Given this list of marker genes MRC2, IRAK2 (NCBI Gene Id 3656), STK39, SEH1L, KRCC1, MYB, TM9SF3, ETF1, EIF4E, GRIPAP1, ZNF784, TESK2, UST, EIF4H, UBFD1, TMCC1, PKP4, SGMS1, TADA1, ACBD3, FBXW11, FOXP1, MAP3K12 (mitogen-activated protein kinase kinase kinase 12), STX5, GLDC, NAV2, PAFAH1B1, PAPPA, SRF, VAMP2, DYRK1A, GABRG2, IKBIP, MBD6, MMP19, ELK1, ICA1, MYADM, ERP44, PLXNC1, GTF3C2, ERC1, VEZF1, COL4A4, EDA, ZCCHC3, TAPT1, IFFO1, ZBTB4, FZD4, ACTR1A, ZMYM5, TSC22D3, RAD23B, BASP1, IGF1, EGR2, ARGLU1, ATAT1, HILPDA, EPHB2, PIGA, MMP14, KCNN3, GDI1, PRKAR1A, ZNF189, DUSP3, NOTCH3, C2CD2L, PRRT2, SMARCD1, PPP2CB, ARAP3, PLP2, CPD, PA2G4, YDJC, TRPS1, VEGFA, NR2F2, SRSF2, FOXO4, GPATCH8, MIB1, KLHL3, DHX36, PFN2, POM121, GGNBP2 (NCBI Gene Id 84160), here is a description of the gene set: Human Gene Set: TTGGGAG_MIR150 Genes having at least one occurence of the motif TTGGGAG in their 3' untranslated region. The motif represents putative target (that is, seed match) of human mature miRNA hsa-miR-150 (v7.1 miRBase). studied in species Homo sapiens